The following is a description of a gene set: Mouse Gene Set: GOBP_PEPTIDYL_TYROSINE_AUTOPHOSPHORYLATION The phosphorylation by a protein of one or more of its own tyrosine amino acid residues, or a tyrosine residue on an identical protein. studied in species Mus musculus, and this is the list of marker genes: Aatk, Ntrk1, Iqgap1, Mapk3, Ddr1, Egfr, Kdr, Nrg1 (NCBI Gene Id 320603), Grem1, Ptk2b, Lck, Insr, Cav1, Srms, Ctnnd1 (catenin delta 1), Ptk2, Alk, Igf1r, Dyrk1a, Ros1 (NCBI Gene Id 19886), Ltk, Abl1